Given this list of marker genes PFKP, HKDC1, NUP58, POM121C, SLC37A4, GNPDA2, GAPDHS, TPR, PPP2R1A (NCBI Gene Id 5518), SEH1L, PFKFB2, BPGM, ALDOB, NUP54, PFKFB3, ADPGK, POM121, PGAM2, NUP35, PPP2R1B, NUP107, G6PC2, NUP210, NUP88, AAAS, SEC13, GAPDH, NUP205, NUP93, NUP153, PKM, RAE1, NUP62, NUP155, PC, PRKACA, HK1, PRKACG, NUP37, NDC1, PPP2CA, PFKM, NUP214 (NCBI Gene Id 9680), GNPDA1, ENO3, NUP42, PFKL, ENO1, PGAM1, PRKACB, PPP2CB, HK3, PPP2R5D, HK2, PGM2L1, SLC37A1 (solute carrier family 37 member 1), ALDOC, PGK1, NUP188, G6PC3, ENO4, NUP50, NUP133, PCK1, SLC37A2, ALDOA, PCK2, PKLR, PGK2, GPI, TPI1, PFKFB4, NUP85, NUP98, GCK, RANBP2, PFKFB1, G6PC1 (NCBI Gene Id 2538), FBP1 (NCBI Gene Id 2203), GCKR, FBP2, ENO2, NUP160, NUP43, here is a description of the gene set: part of: Metabolism of carbohydrates and carbohydrate derivatives Reactome Pathway: Glucose metabolism species: Homo sapiens Glucose is the major form in which dietary sugars are made available to cells of the human body. Its breakdown is a major source of energy for all cells, and is essential for the brain and red blood cells. Glucose utilization begins with its uptake by cells and conversion to glucose 6-phosphate, which cannot traverse the cell membrane. Fates open to cytosolic glucose 6-phosphate include glycolysis to yield pyruvate, glycogen synthesis, and the pentose phosphate pathway. In some tissues, notably the liver and kidney, glucose 6-phosphate can be synthesized from pyruvate by the pathway of gluconeogenesis.